The following is a description of a gene set: Neighborhood of TIMP2 Human Gene Set: GNF2_TIMP2 Neighborhood of TIMP2 TIMP metallopeptidase inhibitor 2 in the GNF2 expression compendium studied in species Homo sapiens, and this is the list of marker genes: VGLL1, PSG5, PSG4, PLAC1, LGALS14, ADAM12, INSL4, PSG3, CAPN6, KISS1, CRIM1, PSG2, HSD17B1, EGFL6, CSH1, SVEP1, PAPPA, AOC1, CRH, ADM, PSG6, RHOBTB1, PSG1, MAN1C1, IGFBP1, PAPPA2, MMP11, SEMA3B, S100A10, EGFR, TFAP2A, GCM1, LEP, FBN2, GH2, PSG9, CDKN1C, TIMP2, EBI3, HSD3B1, GDF15, MAFF, PSG7, CYP19A1, PAGE4, ALPP